The following is a description of a gene set: from publication Prots I, Skapenko A, Lipsky PE, Schulze-Koops H (PMID 21347372) species: Homo sapiens CD25+ regulatory T cells develop in the thymus (nTregs), but may also be generated in the periphery upon stimulation of naive CD4 T cells under appropriate conditions (iTregs). The mechanisms that regulate the generation of peripheral iTregs are largely unknown. We used microarrays to gain insights into the molecular program of extrathymic Treg development. Genes up-regulated in comparison of naive T cells at day 0 versus CD25+ regulatory T cell (Treg) treated with IL4 at day 7. Human Gene Set: GSE24634_NAIVE_CD4_TCELL_VS_DAY7_IL4_CONV_TREG_UP, and this is the list of marker genes: GOLGA3, PODNL1, ABCA7, PPFIBP2, SC5D, ZSCAN18, INTS15 (integrator complex subunit 15), RNF139, MTCL2, HAUS3, RYK, TCF7, SIK1, FGF9, RELA, CYFIP2, CAST, SAMHD1, FOS, BRD9 (NCBI Gene Id 65980), FHIT, ZC3H12A, ATM, PER1, COQ10B, LRPAP1, KLF11, KLHL28, TLE2 (TLE family member 2, transcriptional corepressor), BBX, ZNF516, PTPRA, BCL11B, TUG1, CDR2, PLCL2, NELL2, TSC22D1, SATB1, CDIPT, PIAS1 (protein inhibitor of activated STAT 1), JADE2, ATXN7, CFAP410, NGDN (NCBI Gene Id 338007), GARRE1, KRT18 (keratin 18), ARRB1, IGFBP7, SF1, KANK1, PGGHG, BBOF1, ZNF510, RWDD3, SPPL2B, PTGER4, FOXO1, CFAP74, C9orf78, PTP4A1, RAB9A, KBTBD11, RNF38, LRRC14, PPP1R13B, TSPYL2, GABARAPL1, LARS1, IER2, PRKAB2, HLA-F, TNFAIP3, SUCO, JUND, YJU2B, SLC16A6, SGSH, XPO6, SECISBP2L, PLCH1, SLC7A6, MOB4, MVK, REX1BD, VPS51, REXO4, UVRAG, PIK3IP1, PARP6, DGKZ, XKR8, FBXW4, GATAD1, OSER1, LPCAT3, KLHL36, SAP30BP, ZFP36, PTGER1, C1orf54, MOAP1, SMAD7, CGGBP1, TSR1, MSL1, ZNF492, TCF20, TTC3, ZNF239, GADD45B, SIRT1, ARL4C, GOLGA8H, FAM117A, CGRRF1, SMAGP, FLT3LG, KANSL2, CROCCP2, DDX5, MGAT4A, CEP68, ZNF329, TOE1, TENT5C, NXF1, PRDM4 (PR/SET domain 4), C10orf95, RRAGB, TOB1, VWA8, SLC25A16, PDP1, TPST1, MARK3, KLHL21, RHOT2, DGAT1, ACACB (acetyl-CoA carboxylase beta), STRN3, ATG9A, SMURF2, ATF7IP2 (NCBI Gene Id 80063), E4F1, PQBP1, RFX1, FBXW12, PATZ1, MAN1C1, POPDC2, ZNF573, TP53BP2, DMBT1, SPEN, RPL10L, RPL28, GNPTAB, PCIF1, DIDO1, KCNH2, SH2D3A, FLNB, ZNF506, AKAP8L, FAM53C, SEMA4F, ZBTB40, TGFBRAP1, DCAF16, ANK3, MTCH1, ZBTB20, TNFSF8, MAD1L1, KLF13 (NCBI Gene Id 51621), SGF29, MAU2, ZNF263, ZNF34, TMEM185B, RNF125, LONP2, GAL3ST4, TRIM22, MED13L, CXCR4, CDC37L1, JOSD1, PFN2, FNDC3B, SPSB3, MNT, ITGA5, JADE1, TCTA, MSL2, ATG14, DBP, SPECC1L